The following is a description of a gene set: Human Gene Set: GOMF_ENZYME_REGULATOR_ACTIVITY Binds to and modulates the activity of an enzyme. studied in species Homo sapiens, and this is the list of marker genes: GCN1, DFFA, EIF2AK2, TBC1D3L, CST9LP1, RABGAP1L, CSTL1, PIM1, SLC38A9, RECK, OPHN1, MMP16, ABCA2, ARHGAP25, APOH, CCNT2, IQGAP2, GPSM1, BTRC, RABGAP1, TIMELESS, TTN, SH3BP5 (SH3 domain binding protein 5), POLG2, RIC8B, ANGPTL4, NRG3, CST8, SH3RF2, TMX1, HPS4, SRGAP3, WNT11, RPS15, ARHGAP31, TBC1D30, AHSG, MYOZ1, TBC1D12, GRM7, ARHGAP27, KIAA1755, UCN, JUN, PTP4A2, RGS5, PRKRIP1, ALKAL1, TCL1A, GUCA1B, TNKS1BP1, DOCK11, EIF2B4, TBC1D3C, IQSEC2, PIK3R3, AREG, ARHGAP11B (Rho GTPase activating protein 11B), BIRC5, NCOR2, ARHGAP32, HMGB1, SERPINA9, LAMTOR5, RAB3IP, CD40LG, CCNJ, TBC1D22A, EPS8L1, RCC1L (NCBI Gene Id 94293), ELP3, SPINK7, UGT1A9, GDPGP1, ARHGEF1, DUSP3, AIM2, DENND4C, ARHGAP18, RGPD8, CABIN1, ASAP1, PRSS22, MYCBP2, DDX3X, ABI1, SMR3B, CCKBR, TBCK, PSMD2 (NCBI Gene Id 5708), CDC20, DBNL, BTC, FAM47E, RGL2, ARHGAP15, PDGFRA, PINLYP, AMBRA1, ZEB2, CDKN1A, PTN, ARAP2, LILRB4, DNMBP, PPP1R26, PPP6R1, PPP2R2C, RASAL1, GNAI1, SESN2 (sestrin 2), ARHGEF9, MAP2K1, SIPA1L3, ARFGAP1, TAOK2 (NCBI Gene Id 9344), RAPGEF6, PPP1R17, SPOCK3, UCHL5, MON1A, PINK1, SPINK5, CST11, CIT, CCND1, GLMN, RGS7, KALRN, TEN1, PARK7, PPP2R2B, PHACTR3, P2RY12, MSH2, PARP8, STRADA, TBC1D24, SERPINE1, CALML5, PPP2R3B, CIB1, CDKN2A, SOCS1, PIK3CA, GDF2, IFIT1, TIMP3, SEPTIN2, DMWD, RGS18, HSP90AA1, HACD3, IGFBP2, SEC23A, CSTA, ITIH4, PLEKHG3, GDI2, RALGPS2, APOC3, SMR3A, PPP1R15A, MT3, DENND2C, HOPX, LGALS3, RAB3GAP1, GPRC5B, BTK, ARHGEF40, ARHGEF10, ARHGAP21, DMPK, PDCD5, PARP6, ITIH6, MCF2L2, VCP, CASP3, TBC1D8B (TBC1 domain family member 8B), WFDC3, ARPP19, RACGAP1, BMI1, BMP7, TESC, CWF19L1, CCNJL, SERPINB3, NANOS3, CASP8AP2, PPP1R27, PPP2R1A, CST7, MCRS1, PLCE1, DENND1B (NCBI Gene Id 54530), SPRY2, NDUFA13, STK11, EZHIP, PSD2, PLEKHG5, TPX2, ARHGEF39, RENBP, RGPD6, CCL5, ARHGAP22, EPS8L3, C1QBP, PRKCD, PPP1R16B, NOD1, NLRP3, PPP2R5B, NF1, AGAP2, RPGR, SCG5, CALM2, ANP32E, CCNB2, QARS1, GNAL, THG1L, FAM13A, GAPVD1, EFCAB11, SAG, ARHGEF37, CALM1, DENND6A, WDR4, PPP1R11, SERPINC1, TP53, PRPSAP2, SPINK13, GRIPAP1, DUS2, DUSP22, GRB2, PRKAR1A, NAA16, RASGEF1C, TAOK1, ADGRB3, ARHGEF2, ADRA2C, GTF2F1, LAMTOR1, GUCA2A, GM2A, BEX3, PARVA, PSMF1, CYTH3, RALGAPA2, HPS1, CCNL1, CIP2A, MAPK8IP1, ARHGDIG, PTGIR, GNAQ, CDK4, RASA3, RABGEF1, SERPINB10, CHN1, CCDC88A, SERPINA10, PDPK1, ARHGAP17 (NCBI Gene Id 55114), COL7A1, GIT2, RGP1, PPP6R3, DENND1C, COQ9, TIMP1, SERPINA3, DAD1, TBC1D5, THADA, VRK3, SERPIND1, CLPSL1, ARFGAP2, TIMP2, NGEF, MOB1B, CLPS, WDTC1, GAS6, HDAC6, EIF2B1, ABHD5, PHACTR2, APAF1, RALBP1, TRIB2, ARHGAP42, CDKN2D, XRCC5, PPP2R5C, RHOF, RPS7, ARHGAP28, RGS17, CCNO, CHML, MOB3A, PCSK1N, PRKAG1, NLRP1 (NCBI Gene Id 82286), BCR, DOCK1, PTPA, MOB3B, GCKR, CCNB3, PPP4R3C, SERPINB4, DYNLL1, MOB1A, RGPD3, PPP1R14C, CCNY, RAPGEFL1, ARHGAP30, PPP1R8 (NCBI Gene Id 5511), TBC1D19, VEGFA, RIN1, ARFGAP3, PTPRC, EBAG9, INCA1, RHOD, RGL4, CHN2, ITIH2, RGPD4, SERPINA7, CRB2, NRG1, WAS, SERPINA12, MLDHR, CCNE1, DNMT3L, SERPINF1, SLN, MAPK7, TIAM1, NBN, ARHGEF7 (Rho guanine nucleotide exchange factor 7), KAT2B, CDKN1C, PPP1R14B, DENND2B, ARHGAP40, RASA2, OPRPN, ERCC5, TBC1D22B, PLCD4, NOS1AP, NCF1C, CD33, CCNF, MSTN, PPEF2, ELP4, ERRFI1, STYXL1, CST9L, DOCK7, RGS10, FGD3, PPP1R16A, RANGAP1, RGS8, CCNH, DOCK10, TBC1D26, PLAA, RAPGEF1, PPP1R14D, CAB39L, CCNA2, A2ML1, ADIPOQ, PRDX3, PPP1R1A, GSKIP, CST3, SERPINE3, ASAP2, ABR, DENND4A, RAP1A, ITIH3, IGF2, RASAL2, DEPDC5, MNAT1, RASGRF2, DOCK8, FARP2, MOB3C, PPP1R36 (protein phosphatase 1 regulatory subunit 36), ANKRD27, HTRA2, GNB5, KRTCAP2, DTX3L, HRG, SIPA1L1, BMP2, RGL1, CCNK, COL4A3, GCGR, UGT1A3, CCNB1, MACROH2A1, FNTA, C3, EIF2B5, LYN (NCBI Gene Id 4067), SPRED2, STARD8, SERPINB5 (NCBI Gene Id 5268), PTTG1, CYTH4, FGD4, GHRL, FXN, ALS2, RCVRN, SERGEF, SWAP70, GPRC5D, BCL2L13, SLX4, ROCK2, TBC1D3D, NHERF4, RGS4, NCF1, HSPBP1, RCAN2, RASA4, WFDC13, SPDYA, ABL2, CNEP1R1, APLP2, AMBP, RIMS1, BOD1, HSPA5, RPLP1, RANBP10, PARP16, ARHGEF18, RASGEF1A, LCK, ARHGEF12, RAC2, HERC2, WRNIP1, UGT1A8, CRY2, VIL1, RGS14, PPP6R2, ARHGEF17, ECT2, CSN2, SERINC2, C4A, CARD16, TANK, SGSM2, PDGFRB, DEPDC1B, PPP2R2D, OCRL, ARHGEF15, ATP6V1H, DENND6B, PPP1R2B, MAP3K12, ANXA2, SPINT2, ANXA5, GCHFR, MAP3K13, RGN, LIMK1, FNTB, TBC1D15, AXIN1, DNM1L, SPINK6, ARHGEF19, SPINT4, FRMD7, RGL3, PPP4R1, SFRP2, RCC2, ARRB1, SSPOP, SOS1, UBE3D, FN1, FAM13B, CPAMD8, ARHGEF28, GPRC5C, PRKRA, AGAP5, APOE, CRIM1, STK3, WFDC8, CST1, SERPING1, TBC1D9, TBC1D10B, CDKN1B, PCNA, CST6, STRIT1, TBCD, LTC4S, HSPB1, ARHGAP6, RAP1GAP2, VPS9D1, SFN, GRM5, PSMC3IP, AGAP11, GNA12, DENND2D, PDGFB, CBX8, SBF1, ACAP3, APOC1, AGFG1, CAMK2N2, SERPINB2, SLCO1B3-SLCO1B7, CSTB (cystatin B), GMIP, CCDC88C, ANXA1, C5, DCP1A, TFPI, SDHAF4 (succinate dehydrogenase complex assembly factor 4), DOCK9, SERPINA5, NCK1, PPP4R2, ADRM1, RAMAC, TBC1D14, SERPINA6, RALGPS1 (NCBI Gene Id 9649), DENND5B, TIFAB, BIRC3, RCAN1, EIF2B2, ARFGEF2, PIN1, BMP4, BRPF1, HBEGF, EPPIN (NCBI Gene Id 57155), PAPLN, NCSTN, FYN, TRIB1, PRKCH, SPRY4, ARHGEF26, BCAR3, NANOS2, BIN1, CDC20B, STXBP5L, SLPI, EIF2B3, PPP4R3B, GPS1, FBLN1, ADAP2, SH2D3A, ARHGEF6, FZR1, PZP, TNFAIP8, EEF1D, CST5, HMSD, CABP1, SERPINA2, IPO5, ELMOD3, GPIHBP1, PPP1R10 (NCBI Gene Id 5514), CARD18, NOTCH1, CCNG1, PPP1R7, FLT3, SERPINB9, GMPPA, TBC1D2, HTR2A, RTKN, RAPGEF4, B3GAT3, PAK1IP1, MCF2L, PCOLCE2, HRAS, CARD8, UVSSA (NCBI Gene Id 57654), PYDC1, APP, CCNT1, SOCS3, PI3, CXCL1, CALM3, PLEKHG4, VCAN (NCBI Gene Id 7902), HERC1, SERPINA1, SERPINI2, RPTOR, PREX2, ALDH1A1, UGT1A7, VAV3 (vav guanine nucleotide exchange factor 3), SCGB1A1, TGFA, PPP2R5E, TRIB3, ARHGEF10L, PABIR2, ATG13, ANOS1, PSMD3, BMP2K, UGT1A6, LCN1, EFNA5, ITGA1, IRGM, TBC1D10C, CLPX, CAST, SERPINB7, SEC23B, AHCYL1, CCNC, EVI5L, ANKRD42, ATAD3A, NLRP7, RALGAPA1, C4B, MYO9B, LTK, DGKQ, NOXA1, STXBP5, HSP90AB1, FERMT2, PLEK, PCP2, THBS1, PSME3, SPINK8, PIK3R2, GDF10, SPRED1, INKA1, YWHAE, POR, MRLN, CKS2, SBF2, PPP1R2 (protein phosphatase 1 regulatory inhibitor subunit 2), ING2 (inhibitor of growth family member 2), FGD6, IQGAP3, ARHGAP23, CPEB2, LLGL2, WDR81, GNA13, ITGB1BP1 (NCBI Gene Id 9270), DPM2, IGFBP3, WDR41, PSD3, MAT2B, PDE8A, ATP5IF1, SERINC1, APOC2, AJUBA, TAOK3, CFLAR (CASP8 and FADD like apoptosis regulator), PPP2R5D, PPP4R4, TPRN, ARHGAP24, SYDE2, ATP2A3, SAV1, TBC1D25, SOS2, GPRC5A, WFDC1, CCL3, LTF (NCBI Gene Id 4057), TRIM23, IPO7, FAM20A, SGSM1, FAF1, EIF5, PRKAR2A, TREM2, FGD5, SPINT1, RASA4B, ITIH1, ARHGAP1, RASA1, RGS3, CDC42EP2, CDC37, CTSC, CAPN3, FAF2, TBC1D3I, FRY, IL6ST, PDC, VAV2, PABIR1, ARHGAP9, NCKAP1L, RACK1, LGMN, ERCC4, APOA2, HSP90B1, GRTP1, DAB2IP, PDE6D, AGFG2, TESK1 (testis associated actin remodelling kinase 1), MANSC4, PABIR3, PIK3IP1, SH3PXD2B, PPP1R14A, SIRPA, ANKLE2, FURIN, PPP1R2C, STRADB, DNAJC3, ALKAL2, WFDC12, HMGCR, AGAP3, MLST8, ELFN1, ARHGAP45, RGS12 (regulator of G protein signaling 12), RICTOR, PKIB, RINL, ARHGAP12, CARD17P, NPRL2, DBF4B, SERPINH1, KRIT1, STYX, SMAP2, CLPSL2, PINX1, GHR, RAPGEF5 (NCBI Gene Id 9771), CD24, TBC1D9B, NUPR1, KNDC1, ENSA, IGBP1, CD109, INSR, TFPI2, MAP3K20, DENND4B, NOXO1, PDE6G, ABL1, CDK5R1, SYNGAP1, HSPD1, RCC1, CASP9, MMP24, GNAZ, TMBIM6, BAG5, NCF1B, GDI1, WFIKKN2, SERPINB1, SUZ12, ARHGEF25, YWHAG, GUCA2B, CKS1B, CCND2 (NCBI Gene Id 894), CST2, RAPGEF2, SLCO1B3, SSBP1, CPN2, STK4, SAE1, PPP3R2, MYO9A, DEF6, DELE1, SPOCK1, NET1, BRCC3, LRRK2, GPC3, ARF4, DLC1, DENND11, TBC1D3E, ATG14 (autophagy related 14), TNK2, CAB39, LRCOL1, SERPINI1, BIRC6, NAP1L2, GMFG, SORL1, PREB, PRKAG2, NCF4, ARHGAP29, AGAP7P, RPL11, APOA4, SLC39A10, XIAP (X-linked inhibitor of apoptosis), WASHC1, SERPINE2, OTUB1, TIMM50, SPINT3, CCNI2, GBF1, RANGRF, ARL1, IRS2, SH3GLB1, PLEKHG6, KDM5A, RGS11, PLCG1, FLCN, ELMOD2, HEXIM2, FARP1, KLF4, LXN, TBXA2R, ACSL1, SHOC2 (NCBI Gene Id 8036), AGAP4, PKIG, RGS2, PSMD1, PCOLCE, AGT, PHACTR4, TBC1D8, DAXX, IQGAP1, PARP1, PPME1, GPR158, COL6A3, CHM (NCBI Gene Id 158677), HYAL2, PLEKHG2, SIPA1, GPSM3, ADAP1, FGD1, MLH1, MMP15, PSD4, PRDM14, SKI (NCBI Gene Id 6497), LAMTOR4, FETUB, URI1, ACD, ARHGAP33, RIC8A, PI16, CDC42SE1, CCNA1, RASGRF1, GNAO1, NAA25, RIC1, ELMO1, SERPINA4, MGAT5, RASGRP1, TNFSF14, TBC1D1, AGAP6, RANBP1, ARHGEF4, AKT1, TRMT112, WFDC6, GNAS, ADGRV1, MTMR9, PPP2R2A, NUCB2, MID1IP1 (NCBI Gene Id 58526), COL28A1 (collagen type XXVIII alpha 1 chain), SIRT1, CALML4, MAP2K2, STARD13, RASGEF1B, GPS2, RGS20, C3P1, YWHAB, PPP2R5A, PRKD1, HSPB2, FBXO8, PITRM1 (NCBI Gene Id 22910), WFIKKN1, DIS3, EREG, APBA3, DEPTOR, ENTREP1, DEPDC1, PARP9, CCNI, TAB1, PYGO2, NANOS1, PDE6H, FRS2 (NCBI Gene Id 10818), WDR6, TBC1D3K, DENND3, ARHGAP8, SRC, UBE2L3, ARHGAP11A, RAF1, ADRA2A, ALS2CL, MAPRE3, PLXNB1, TAGAP, DDOST, GAPDH, VAV1, BID, EPO, TBC1D20, GIT1, UMODL1, THY1, PRKAR2B, TBC1D16, SH3BP5L, NOL3, RHOU, SPATA13, SET, CYTH2 (NCBI Gene Id 9266), FNIP1, NCF2, TBC1D3F, AGAP1, SMO, KNG1, RAB3GAP2, APH1A, NRP1, WFDC11, MAL, SVBP, MIA2, RASGRP2, RPL23, MAPK8IP2, C9orf72, ARHGAP20, COX6A2, CYTH1, WFDC5, PRNP, CDCA2, LARS1, CCNQ, SLC27A1, SH3PXD2A, SERPINB13, AZIN2, SERPINB12, CAMK2N1, GUCA1A, RPL37, ITPRIP, FGD2, TSC2, MAPK12, CCNE2, RGS9, RAPGEF3, CST9, GBP5, TRIO, AFAP1L2, WDR20, GMFB, PRPSAP1, MOB2, PI15, DENND1A, FBXW7, DPM3, RPL5, RHEB, MGST2 (NCBI Gene Id 4258), ESR1, SNCA, PLA2R1, USP14, NGB, SMAP1, MBIP, PSME1, CNPPD1, ARL2BP, ITSN2, RBCK1, GNA11, TIMP4, RCBTB2, IQSEC3, PRKAG3, PPP1R9B, DNAJA3, UGT1A10, SPP2 (NCBI Gene Id 6694), PIK3R5, AKAP13, TGFBR2, BST2, EGFR, ARHGAP19, MAPK8, TGFB1, ELMOD1, ARHGAP4, ARHGEF3, GUCA1ANB-GUCA1A, SYDE1, TBC1D3B, USP6NL, ARHGAP26, CCNL2, PRKCE, CTNND1, WARS1, PHACTR1, ARHGEF11 (Rho guanine nucleotide exchange factor 11), TBC1D10A, PPP1R35, DENND2A, TBC1D4, IBTK, ARFGEF3, CD27, RASAL3, BRAT1, SIPA1L2, RFC1, SAMD15 (sterile alpha motif domain containing 15), SLIT2, PELO, SRGAP1, RUNDC3A, CHP1, WASL, RAB3IL1, APH1B, CASP1, ETAA1, RGPD5, EGLN1 (NCBI Gene Id 54703), ARHGAP5-AS1, SPINK2, NKX3-1, LAMTOR3, BAD, ITSN1, CCAR2, HEXIM1, AGAP9, RALGDS, MTSS2, ABCE1, PROS1, RASGRP4, ASAP3, RABEP1, ANXA3, ANGPTL3, EED, CDKN2C, HTR2B, PPP1R15B, RALGAPB, OAZ2, ZNF598, ST20 (NCBI Gene Id 400410), AZIN1, R3HDML, ERBB3, RAP1GAP, DOCK2, CSNK2B, RING1 (NCBI Gene Id 6015), SIMC1, RIN3, ANXA2P2, STX4, PSENEN, RGPD1, ACVR2B, PPP1R1B, CST4, CCL8, VSIR, RGS6, PPP2R1B, SH3BP4, PTEN, CCZ1, TBC1D3, APC, MARK2, WDR91, ACAP1 (NCBI Gene Id 9744), DDX21, CALML6, DOCK6, TCL1B, SMCR8, ANXA8, PEBP1, ARHGAP44, PPP1R12A (protein phosphatase 1 regulatory subunit 12A), PPP1R3B, SLCO1B7, ITIH5, EVI5, MADD, ARFGEF1, DCP1B, OAZ3, NEK9, TOPBP1, DENND10, SRGAP2, AKT1S1, MCF2, MMP17, ECT2L, TBC1D13 (NCBI Gene Id 54662), WNK1, RGS16, WFDC2, NLRC4, EEF1A1, GCLM, EEF1B2, SH2D3C, BIRC8, ARAP3, PPP1R2P1, NAIP, ANKRD54, UGT1A1 (NCBI Gene Id 54658), GSTP1, BIRC7, ARHGAP36, NAA15, ANXA4, NCS1, RANBP2, ARHGEF38, BCAS3, RIN2, PLN, ANGPT4, TIPRL, PLEKHG1, TEFM, PHPT1, PPP4R3A, DOCK4, COQ8A, ARHGAP10, COX17, BNIP2, CCNG2, IQSEC1, PAK2, TIAM2, RGS1, CCNP, RABIF, SPINK14, SERPINF2, GREM1 (NCBI Gene Id 7947), A2M (alpha-2-macroglobulin), WFDC10B, ARHGAP5, SPOCK2, GUCA1C, MTCP1, CCND3, PLCB1, EGF, RUBCN, PKIA, RNH1 (ribonuclease/angiogenin inhibitor 1), ALOX5AP, DBF4, DAZAP2, INKA2, BIRC2, LLGL1, WDR48, PIF1 (PIF1 5'-to-3' DNA helicase), PIK3R6, TXNIP, PPP3R1, PSMD14, PRDX5, PLEKHG4B, SIRT6, SERPINB6, CXCL10, PPP1R37, UBE2N, PPP5C, LMTK2, TOM1L1, RARRES1, NPM1, PYCARD, COX6A1, CLSTN3, IL2, PIK3R1, LAMTOR2, ACAP2, RAP1GDS1, PSME2, WFDC10A, MALT1, SPINK9 (serine peptidase inhibitor Kazal type 9), ARAP1, RGPD2, CEP43, OAZ1, ATP2B4, SGSM3, ETFRF1, STAP1, UGT1A4, PSD, POT1, PEX12, LRP6, SH3BP1, ELFN2, IGF1, BCCIP, WFDC9, PPP2R3A, FBXO5, APOA5, TBC1D17, RAD50, FOXL2, NGF, SERPINB8, CDKN2B, TBC1D3H, LPA, OBSCN, DOCK5, RCAN3, EPS8L2, SNCB, RPS20, GARNL3, BSN, SERPINB11, ARHGDIB, SPINK1, GPSM2, ARHGAP39, PREX1, TBC1D3G, SEC61B, RHOH, ARHGEF33, ARHGEF16, EPGN, ARHGDIA, RGCC, RASGRP3, DUSP19, DOCK3, TBC1D2B, SPINK4, NUCB1, TBC1D21, KIDINS220, CDK5R2, RABEP2, TBC1D7, ARHGEF5, PLEKHG7, PSME4, ALK, PSAP, PPP1R12C, PRKAR1B, ERCC6, GBP2, CTSA, RP2, SERPINA11, NRDC, CAV1, NPRL3, CTSH, DENND5A, NLRP12, PPP1R12B (NCBI Gene Id 4660), APOA1, PPP1R1C, ACTB, ARHGAP35, BCL10